Given this list of marker genes KCNE3, CASP2, BCL11A, TTK, PTPA (NCBI Gene Id 5524), PSMB4, GNPTAB, POLR1C (RNA polymerase I and III subunit C), CORO1A, CERS6, RAD54L, UQCRC2, EIF3M, CCNA2 (cyclin A2), PTPN18, RPLP0, CXCR3, UBE2K, DUSP2, NPM1, LSM4, LY75, LBH, KIF2C, INTS6 (NCBI Gene Id 26512), CKS2, PSEN2, PPA1, KCNAB2, RFC4, PUM3, NPEPL1, ARL4A, IL18, HIP1, MICAL1, PAK1, SUPT3H (NCBI Gene Id 8464), TOMM22, CLDN1, RTCB, NDRG1, POLA1, COPS5, POLR1H, COX17, MRPL52 (mitochondrial ribosomal protein L52), CLEC7A, SATB1, CCDC88A, ACOX3, TSPAN2 (NCBI Gene Id 10100), POLD1, ACP1, SPACA9, CISD1, MRPL58, DDX3Y, FKBP8, ABTB2, TEX10, CCL22, POLR2H, CFAP36, PLTP, GPI, RNASE3, NDUFA6, ATP5PF, BANF1, OCSTAMP, MAGOHB, PDLIM7, TRAPPC5, LSM5, RPS3A, ATG3, DKC1, MICU2, MRPL41, RBCK1, FYN, GRK5, BRCC3, LYAR, STK24, SNRNP25, TIMELESS, ACAP1, SAMHD1, BAIAP2, DCK, SNRPD1, H2AJ, ZNF593 (zinc finger protein 593), RAB11FIP4, CCDC92, RAB21, NHP2, PALLD, MPPE1, CFAP107, PIH1D1, MRPL22, PSMA1, NUDT5, RCN3, STX7, NXT1, MBOAT1, DR1, HSH2D, ATP5PB, MYRFL, PITPNM1, SDC3 (NCBI Gene Id 9672), ELAC2, CEP43, CBFA2T3, POU2F3, ALDH9A1, STK38, TNFAIP8L1, CADM1, SLC52A3, CEP83, RPS14, ARHGEF3, TYK2, PPP2R5A, PPT1, PIGY, GNAO1, NDUFA1, DYNLT1, REX1BD, ARL2BP, C1orf54, HMGN5, CCT5, PLPP2, MED21, CFDP1, PPIG, COX8A, SPMIP3, CCR9, SDHB, HSPA2, RPL23A, SNHG6, MRPL33, EPHA5, USP1, MARVELD1, RPS9, SLAMF8, HDAC1, SEPTIN9, HLA-DOA, ERMP1, DBN1, PSMB7, ATP5IF1, CD207, PTRH2, HM13, TAGLN2, CNIH4, UBTD2, GDI2, PTPN22, MIA2, ACACA, MRPS24, NUCB2, NADK, NAA38, REXO2, CETN2, IFT25, SEC61G (SEC61 translocon subunit gamma), MOB3B, SKA1, NAGA, SLC36A3, SSU72, CHCHD1, DEDD2, AKT3, RPP21, CYB5A, TAF13, CD40, SIRT3, AFF3, DYNLRB1, NOP10, PSMA7, CRY1, here is a description of the gene set: Analysis of mobilized peripheral blood CD34+ cells from a healthy volunteer under erythroid differentiation conditions with and without stimulation to the BMP or Wnt signaling pathways. For erythroid differentiation, expanded CD34+ cells were placed in Stemspan SFEM medium supplemented with 2% pen/strep, 20ng/ml SCF, 1U/ml Epo, 5ng/ml IL3, 2uM dexamethasone, and 1uM beta-estradiol. Arrays were performed 2 hours after addition of cytokines. For signaling pathway stimulation, cells were exposed to 0.5uM BIO (a GSK3 inhibitor) for Wnt pathway activation, 25ng/ml rhBMP4 for BMP pathway activation, or vehicle control for 2 hours. Three biological replicates were performed per treatment group. We used microarrays to detail the global program of gene expression changes after Wnt or BMP pathway stimulation in human CD34+ hematopoietic progenitors under erythroid differentiation conditions. studied in species Homo sapiens from publication Trompouki E, Bowman TV, Lawton LN, Fan ZP, Wu DC, DiBiase A, Martin CS, Cech JN, Sessa AK, Leblanc JL, Li P, Durand EM, Mosimann C, Heffner GC, Daley GQ, Paulson RF, Young RA, Zon LI (PMID 22036566) Genes up-regulated in CD34+ cells: control versus stimulated by BMP4. Human Gene Set: GSE26351_UNSTIM_VS_BMP_PATHWAY_STIM_HEMATOPOIETIC_PROGENITORS_UP